The following is a description of a gene set: from publication Chang WL, Coro ES, Rau FC, Xiao Y, Erle DJ, Baumgarth N (PMID 17237394) Genes down-regulated in lymph node B lymphocytes: influenza infection versus un-infected. species: Homo sapiens Human Gene Set: GSE3203_HEALTHY_VS_INFLUENZA_INFECTED_LN_BCELL_DN Influenza virus infection-induced gene expression changes of regional B cells are mediated at least in part through type I Interferon: Our objective is to determine whether the influenza virus-infection induced gene expression changes in regional lymph node B cells are facilitated at least in part through type I interferon. Our specific aim is to compare the gene expression profile of highly FACS-purified B cells in the regional lymph nodes of wildtype and IFNR-/- mice prior to and 48h following infection with influenza virus infection and to contrast this expression profile with that of FACS-purified wildtype B cells activated in vitro with IFN-beta +/- anti-CD86 for 12h., and this is the list of marker genes: CHRNB3, FABP12, TLCD1, SPACA1, MOK, BPIFA2, ADAMTS4, KCTD11, HCAR2, REEP1, ADORA2A, ELAVL2, AKR1C3, TUBA3C, SLC8A1, VSX2 (visual system homeobox 2), TRIAP1, MOS, CCNJL, FGFR2, SNED1, GGACT (gamma-glutamylamine cyclotransferase), SAT2, COPZ2, PAXX, IL18RAP, EIF4G2, MYOZ3, ASAP3, ARL2, HECTD2, OTOS (NCBI Gene Id 150677), ASB11, TMEM86A (NCBI Gene Id 144110), BCL9, TDRD1, GIPR, IRAK1, SLC6A14, ZNF575, SLC20A2, TMEM175, DNMT3L, MCMBP, ARMC6, HYAL2, CCDC73, CTDSP2, F8, SSTR1, CCDC116, OTOP2, C5AR1, CFAP221, F2RL2, GPATCH4, PLCG1, NOTCH3, CCDC85A, SPATC1L, DIXDC1, KCNK6, CDX4, SLIT1, POLR3F, WASF2, ZFP92, CD160, BDH2, GIPC2 (NCBI Gene Id 54810), TPPP3, FNDC9, USP26, CRB3 (NCBI Gene Id 92359), ZNF184, PDP2, LRRC19, MAJIN, SALL4, GCHFR, TRAM2, HOXC6, DSCAML1, TLN2, ABCA8, LRRC71, ABHD15, MALT1, FOXP3, TCF21, CPD (NCBI Gene Id 1362), NEUROG3, MZT2B, LYRM9, DTNA, SNRNP35, CSGALNACT2, MC3R (NCBI Gene Id 8203), SLC10A4, MGAT3, RCAN2, CAMKMT, TXNL4B, ABO, ACTA1, NOL8, KRT16, SUCNR1, FBXL5, LMBR1, NGFR, CEP83-DT, FEZ1, ELAVL3, CYP11B2, INIP, IGFBP6, TMEM230, RPUSD3, REG3G, B3GALT5, TNIP2, KIAA1549L, ADRA2B (NCBI Gene Id 151), DNAJC28, GAREM1, BOK, MYMK, TMOD4, GUCA1A, ALK, TMEM123, ARK2C, KREMEN1, SHBG, PPFIA4, FMO2, NAALADL2, SLC25A27, IPO4, TSR3, SLC35D2, GORAB, ITGA2B, SUMO3, WDR35, COTL1, TNFSF10, AQP5, RNF207, FUT7, RLN1, FUBP3 (far upstream element binding protein 3), BBS10, TLCD3B, SLC39A13 (solute carrier family 39 member 13), APBB1, SLC1A6, PRSS41 (NCBI Gene Id 360226), CD163, CASTOR1, STAP2, KLKB1, DMWD, FAM210A, SNX31, CCDC159, CCDC157, CLEC10A, ARHGEF4, ADGRD1, FRS3, TNPO1, MYO5C, UROC1, TFAP4, SLC39A2, ZNF436, MARCO, TOP3B, TTLL13, UGT3A2, EPN2, CFAP298, SEMA3F, UNC5B, CHSY3, AKR1B10, PCYT1B, SLC3A1, CEP63, HLA-E, CREB3L1, TPRG1, NRXN2, CHRNA9, CA12, TPT1, RSU1, TMEM132A